Given this list of marker genes Izumo3, Ercc2, Clasp2, Mfsd14a, Ncmap, Wdr1, Myoz2 (NCBI Gene Id 80533), Tenm4, Tnnt1 (NCBI Gene Id 21955), Mypn, Garin3, Sppl2c, Sec23ip, Nrap, Tbc1d20, Zpbp, Mobp, AU040320, Tbpl1, Ilk, Sox30, Ugt8a, Phldb2, Actl7a, Mios, Mylk3, Pfn4, Pdcl2, Capn3, Garin1b, Dcaf17, Nectin2, Vps13b, Plec, Tmprss12, Flii, Acrbp, Agfg2, Lmod2, Pals1, Ankrd23, Prkar1a, Lmod3, Cflar, Csrp2 (NCBI Gene Id 13008), Six4, Mef2a, Pikfyve, Myom3, Chn2, Rab1a, Poc1b, Nkx2-5, Epb41l3 (NCBI Gene Id 56528), Mybpc3, Ldb3, Spink2, Tppp, Synpo2l, Srf, Cav3, Gnpat, Actg1 (NCBI Gene Id 230535), Adprhl1, Neurl2, Tmod4 (NCBI Gene Id 50874), Ihh, Tmod1, Cfl2, Klhl41, Myom2, Rfx2, Pla2g3, Myom1, Prx, Agfg1, Lmod1, Fig4, Tnnt3, Itgb1, Phldb1, Csrp1, Clasp1, Myl2, Myh11, Pdgfra, Tmod2, Eqtn, Mybpc1, Nebl (NCBI Gene Id 99452), Fhod3, Csrp3, Flnc, Cd9, Fsip1, Krt19, Garin1a, Tnnt2, Pafah1b1, Nfasc, Gpc1, Tpm1, Acta1, Mag, Fam209, Cylc1, Pllp, Ep300, Casq2, Spaca1, Pmp22, Myh10, Neb, Mtmr2, Pgm5, Myoz1, Abca2, Tmod3, Hdac2 (histone deacetylase 2), Cylc2, Actc1, Actl9, Ccdc136, Prox1, Actn2, Mybph, Ttn, Tlr2, Itgb4, Ckap5 (NCBI Gene Id 97044), Pln, Casq1, Mef2c, Ccdc38 (coiled-coil domain containing 38), Edn1, Xirp1, Cntnap1, Zpbp2, Ccdc42, Bmp10, Tmf1, Akap13 (NCBI Gene Id 76109), Prkd1, Cntn1, Myl9, Slc9a8, Dag1, Pdgfrb, Smad4, Mybpc2, Dicer1, Myh6, Tcap, Mfn2, Krt8, Cavin4, here is a description of the gene set: The cellular component assembly that is part of the initial shaping of the component during its developmental progression. studied in species Mus musculus Mouse Gene Set: GOBP_CELLULAR_COMPONENT_ASSEMBLY_INVOLVED_IN_MORPHOGENESIS